The following is a description of a gene set: Mouse Gene Set: REACTOME_METABOLISM_OF_LIPIDS Metabolism of lipids species: Mus musculus, and this is the list of marker genes: Rab14, Osbpl8, Agpat2, Gba2, Srebf1, Sc5d, B4galnt1, Cpt1b, Lpin3, Mbtps2, Decr1, Smarcd3, Awat2, Gnpat, Slc51a, Cyp8b1, B3gnt5, St6galnac6, Lpcat2, B4galt6, Slc44a5, Cyp4a12b, Fabp1, St8sia5, Fabp5, Hacd1, Ormdl1, Ugcg, Plekha8, Acsbg1, Pten (phosphatase and tensin homolog), Fdft1, Fig4, Plekha5, Pik3cd, Pitpnm2, Crot, Acbd4, M6pr, Alox5, Bmx, Pnpla6, Inpp5k, Gm2a, Alox15, Tm7sf2, Gstm4, Acox3, Hsd17b3, Rab4a, Plaat5, Idi2, Slc51b, Acer2, Akr1b7, Slc10a1 (NCBI Gene Id 20493), Elovl5, Mfsd2a, Tbl1xr1, Gpd1, Oxct2a, B3galnt1, Them4, Ptges2 (NCBI Gene Id 96979), Abcc3, Cyp4f39, Eci1, Vdr, Sgms1, Cyp3a16, Cbr4, Gpx1, Gba1, Akr1d1, Arf1, Acadl, Synj2, Cyp4a10, Gpd1l, Hmgcll1, Ehhadh, Hsd17b12, Pi4kb, Tbl1x, Sgpp2, Gpx4 (NCBI Gene Id 625249), Pcca, Cyp2d22, Vac14, Etnppl, Slco1a4, Ltc4s, Acsl3, Cyp2c65, St3gal2, Hadha, Cers5, Mapkapk2, Acer3, Eci2, Cyp19a1, Srd5a2 (steroid 5 alpha-reductase 2), Plaat3, Mtm1, Cds2, Mogat1, Etnk2, Dgat2l6, Pla1a, Hsd3b8, Hsd17b4, Selenoi, Aldh3b2, Cerk, Them5, Neu2, Asah1, Chpt1, Pla2g12a, Enpp6, Akr1c6, Lss, Hsd17b2 (hydroxysteroid (17-beta) dehydrogenase 2), Acot12, Faah, Akr1b1, Pecr, Ctsa, Pla2g4a, Pcyt1b, Pik3c3, Cers4, Cyp4a14, Pi4k2b, Pip4k2b, Cyp27b1, Ndufab1, Nsdhl, Sptssb, Glb1l2, Hadh, Cyp3a41a, Mid1ip1, Pla2g6, Cpne7, Cyp4a12a, Cers3, Agpat1, Ormdl2, Abcb11, Phospho1, Tnfaip8l3, Acbd6, Elovl6, Plbd1, Hsd17b8, Hacd4, Srd5a1, Pip4p1, Acsl5, Pon1, Pla2g2f, Cga, Ocrl, Cyp46a1, Hsd17b13, Cyp3a57, Pemt, Cyp7b1, Pik3cg, Pik3r2, Cers1, Sgpp1, Cers2 (NCBI Gene Id 99568), Csnk2a1, Serpina6, Pikfyve, Dgat1, Pnpla8, Star, Pla2g10, Dgat2, Agk, Acsbg2, Pip4k2c, Gpat2, Slc44a4, Alb, Pip4k2a, Cyp1b1, Cyp4f14, Osbpl6, Gykl1, Gde1, Lipi, Mvk, Fabp6, Fads1, Fabp2, Gpat3, Gk, Pla2g5, Mtmr7, Mbtps1, Acsf3, Sgms2, Aldh3a2, Acbd7, Cds1, Mmut, Acot7, Pla2g2d, Acat1, Pip5k1b, Lpin2, Arv1, Fabp7, Sphk2, A4galt, Cpne6, Degs2, Abhd4, Ppt2, Crls1, Osbp, Fitm1, Csnk2b, Acads, Gpx2, Acsl6, Rufy1, Glb1l3, Plekha2, Tecrl, Acot5, Decr2, Echs1, Pla2g4e, Acbd5, Ptges3, Akr1b8, Cyp4a30b, Arsk, St3gal5, Smpd3, Tecr, Tnfaip8l2, Gla, Agpat3, Osbpl5, Hsd17b1, Ormdl3, Sgpl1, Pon3, Pla2g2a, Cyp3a59, Akr1c20, Srebf2, Cyp51, Hadhb, Mtmr12, Alox12b, Cyp21a1, Ggt5, Rxra, Stard10, Inpp5d, Crat, B4galt5, Cyp2e1, Rab5a, Cyp4a32, Pomc, Asah2, Pmvk, Alox8, Mtmr9, Inpp5e, Ptpn13, Pnpla2 (patatin-like phospholipase domain containing 2), Plekha6, Hexb, Etnk1, Acad11, Hdac3, Cyp27a1, Cyp1a2, Acer1, Sin3a, Gc, Pik3ca, Chkb, Hsd3b9, Fabp3, Ggps1 (NCBI Gene Id 97873), Pi4k2a, Fa2h, Tmem86b, Slc10a2, Nr1h4, Pik3c2a, Sumf1, Pla2g4c, Pi4ka (phosphatidylinositol 4-kinase alpha), Pnpla3, Agmo, Lpcat1, Cbr1, Mgll, Pccb, Ran, Hsd11b1, Acot8, Stard4, Sacm1l, Idi1, Arsj, Abhd3 (NCBI Gene Id 106861), Mcat, Plekha3, Csnk2a2, Slc25a20 (NCBI Gene Id 97527), Cyp1a1, Cers6, Akr1b10, Nudt19 (NCBI Gene Id 27945), Neu4, Pld2, Ddhd2, Hmgcl, Acoxl, Stard7, Hsd3b7, Mtmr3, Oxct2b, Cyp11a1, Mlycd, Hilpda, Awat1, Pcyt1a (NCBI Gene Id 13026), Cyp24a1, Hacd2, Cyp4f40, Idi2l, Ddhd1, Plekha4, Smpd2, Neu3, Miga2, Sptlc2, Pik3r1, Miga1, Lpcat3, Ugt8a, Cpne1, Kdsr, Ncoa2, Slc44a2, Abcd1 (ATP-binding cassette, sub-family D member 1), Acot9, Oxct1, Enpp7, Scap, Hsd3b4, Ggt1, Pnpla5, Pitpnm3, Tspo, Prkaa2 (protein kinase, AMP-activated, alpha 2 catalytic subunit), Pias4, Agpat4, Alox12, Inpp5f, Mfsd2b, Glb1l, Plpp3, Ptges, Ptgds, Pla2g2e, Galc, Sqle, Helz2 (NCBI Gene Id 229003), Stard6, Mtmr1, Fabp9, Cyp2c66, Ncoa1, Samd8, Hexa, Lta4h, Med1, Pip5k1c, Plpp2, Cidea, Hsd3b2, Acat2, Synj1, Stard3, Acot2, Hmgcr, Ptdss1, Hmgcs1, Aldh3b1 (NCBI Gene Id 67689), Inpp5j, Hpgds, Cyp11b1, Morc2a, Osbpl1a, Cyp3a13, Hmgcs2, Carm1, Inppl1, Fut2, St3gal3, Scd2, Aacs, Abcc1, Tgs1, Cpt2, Chd9, Cept1, Ncor2, Mtmr4, Hsd3b6, Dbi, Pik3c2b, Tafazzin (NCBI Gene Id 78810), Kpnb1, Bdh2 (NCBI Gene Id 69772), Slc44a3, Hacl1, Cyp4a29, Lclat1, Sin3b, Osbpl3, Plpp1, Arsa, St6galnac5, Mboat2, Pgp (NCBI Gene Id 67078), Sptssa, Fdx2, Sbf1, Pik3c2g, Gal3st1, Cyp4f15, Cyp39a1, B3galt4, Mtmr2, Fut1 (fucosyltransferase 1), Sptlc3, Spns2, Sumo2, Cyp4f18, Stard5, Psap, Sphk1, Prkag2, Baat, Acsf2, Srd5a3, Plpp6, Osbpl7, Acot13, Pik3r4 (NCBI Gene Id 97556), Mmaa, Mvd, Acot3, Sumf2, Acly, Cyp3a41b, Fads2, Far2, Cyp2u1, Pik3r3 (phosphoinositide-3-kinase regulatory subunit 3), Inpp4b, Cyp7a1, Liph, Alpi, Gk2, Cyp4a31 (NCBI Gene Id 666168), Acadm (NCBI Gene Id 99793), Pld6, Acp6, Pik3r5, Dpep2, Mecr, Ptgs2, Sptlc1, Arsi, Bdh1, Cyp3a25, Slc25a17, Cdipt, Plb1, Acot4, Lhb, Pla2g4d, Pip5k1a, Alox5ap, Stard3nl, Cyp4b1, Arf3, Inpp4a, Slco1b2, Akr1c21, Hpgd, Pla2g4f, Acsl1, Lpgat1, Fitm2, Acad10, Cyp3a44, Osbpl2, Slc27a5, Hsd3b5, Acaa2, Pctp, Ch25h, Sts, Pon2, Mboat1, Plekha1, Cyb5b, Arsb, Fdps, Hao2, Tnfaip8l1, Chat, Lpcat4, Pla2g3, Aloxe3, Msmo1, Acss3, Acacb, Acox1, Agpat5, Mtmr6, Slc27a2, Ebp, Acot1 (acyl-CoA thioesterase 1), Ppard, Hsd17b14, Osbpl9, Cpne3, Tpte, Hsd17b7, Fdxr, Acaca, Pitpnm1, Glb1, Tbxas1, Cyp3a11, Degs1, Ptdss2, Hsd17b11, Mogat2, Fabp12, Pla2g4b, Ptgis, Hsd3b3, Scp2, Gpat4, Elovl1, Thrsp, Mtmr14, Plaat1, Pla2g15, Tnfaip8, Gpd2 (glycerol phosphate dehydrogenase 2, mitochondrial), Slc22a5, Mcee, Pitpnb, Fabp4, Pla2r1, Hacd3, Smpd1, Cidec, Arsg, Amacr, Elovl2, Slc44a1, Mboat7, Elovl7, Lbr, Neu1 (neuraminidase 1), Dhcr7, Ephx2, Ube2i, Far1, Acsl4, Ptgs1, Tspoap1, Pcyt2, Acadvl (acyl-Coenzyme A dehydrogenase, very long chain), Cyp2j6, Fdx1, Dhrs7b, Dpep1, Cyp2r1, Acot11, Pik3r6, Elovl3, Dhcr24, Acaa1b, Cyp17a1, Ppt1, Phyh, Osbpl10, Pik3cb, Gpam, Smpd4, Acox2, Cpt1a, Cyp11b2, Chka, Hsd3b1, Hsd11b2, Fasn, Ppara, Pla2g1b, Prkab2